The following is a description of a gene set: part of: tRNA processing Reactome Pathway: tRNA modification in the mitochondrion The 22 tRNAs encoded by the mitochondrial genome are modified in the mitochondrial matrix by enzymes encoded in the nucleus and imported into mitochondria. Some enzymes such as PUS1 and TRIT1 are located in more than one compartment and modify both mitochondrial tRNAs and cytosolic tRNAs. Other enzymes such as MTO1, TRMU, and TRMT61B are exclusively mitochondrial.<br>Modifications near the anticodon and near the 3' end of tRNAs tend to affect interaction of the tRNA with mRNA within ribosomes and with tRNA synthetases, respectively. Modifications in other regions, typically in the "core" of the tRNA tend to affect folding and stability of the tRNA. The unusual modification 5-taurinomethyl-2-thiouridine-34 in the anticodon of at least 3 tRNAs is found only in mammalian mitochondria and mutations that affect the responsible biosynthetic enzymes (GTPBP3, MTO1, TRMU) cause mitochondrial dysfunction and disease. studied in species Homo sapiens, and this is the list of marker genes: OSGEPL1, PRORP, TRMT61B, MT-TS1, TRMU, MTO1 (mitochondrial tRNA translation optimization 1), TRIT1, GTPBP3, HSD17B10, TRMT10C, YRDC, PUS1